The following is a description of a gene set: from publication Zhou Q, Brown J, Kanarek A, Rajagopal J, Melton DA (PMID 18754011) Transcription factors expressed in progenitors of exocrine pancreatic cells. studied in species Mus musculus One goal of regenerative medicine is to instructively convert adult cells into other cell types for tissue repair and regeneration. Although isolated examples of adult cell reprogramming are known, there is no general understanding of how to turn one cell type into another in a controlled manner. Here, using a strategy of re-expressing key developmental regulators in vivo, we identify a specific combination of three transcription factors (Ngn3 (also known as Neurog3) Pdx1 and Mafa) that reprograms differentiated pancreatic exocrine cells in adult mice into cells that closely resemble beta-cells. The induced beta-cells are indistinguishable from endogenous islet beta-cells in size, shape and ultrastructure. They express genes essential for beta-cell function and can ameliorate hyperglycaemia by remodelling local vasculature and secreting insulin. This study provides an example of cellular reprogramming using defined factors in an adult organ and suggests a general paradigm for directing cell reprogramming without reversion to a pluripotent stem cell state. Human Gene Set: ZHOU_PANCREATIC_EXOCRINE_PROGENITOR, and this is the list of marker genes: MNX1, PDX1, HNF4A, NR5A2, FOXA2, HHEX, PROX1, ONECUT1, PTF1A, HNF1B, SOX9